Given this list of marker genes H2BC14, H2AB1, SMC4, H2AX, H2BC17, H2BC13, H2BC26, RB1, H2BC11, MCPH1, SMC2, H2BC15 (NCBI Gene Id 8341), H2BC12L, NCAPD3, H2AC4, SET, H2AC6, H2BC5, H2AJ (NCBI Gene Id 83739), H2BC1, H2BC9, H4C1, PHF8, CCNB1, H3C1, H2BC4, PLK1, NCAPH2, H2AC20, CDK1, H2BC12 (H2B clustered histone 12), H2AZ2, H3-3A, H3-4 (H3.4 histone, cluster member), H2AC14 (H2A clustered histone 14), H2BC21, KMT5A (NCBI Gene Id 387893), H2AC7, H2BC3, H2AC18, NCAPG2, H3C15, here is a description of the gene set: Reactome Pathway: Condensation of Prophase Chromosomes part of: Mitotic Prophase In mitotic prophase, the action of the condensin II complex enables initial chromosome condensation.<br><br>The condensin II complex subunit NCAPD3 binds monomethylated histone H4 (H4K20me1), thereby associating with chromatin. Binding of the condensin II complex to chromatin is partially controlled by the presence of RB1. <br><br>Two mechanisms contribute to the accumulation of H4K20me1 at mitotic entry. First, the activity of SETD8 histone methyltransferase peaks at G2/M transition. Second, the complex of CDK1 and cyclin B1 (CDK1:CCNB1) phosphorylates PHF8 histone demethylase at the start of mitosis, removing it from chromatin.<br><br>Condensin II complex needs to be phosphorylated by the CDK1:CCNB1 complex, and then phosphorylated by PLK1, in order to efficiently condense prophase chromosomes. species: Homo sapiens